Given this list of marker genes Rps27a, Cdc20, Uba52, Ubb, Fzr1, Ubc, Fbxo5, Uba52rt, Cul1, Skp1, here is a description of the gene set: Mouse Gene Set: REACTOME_SCF_BETA_TRCP_MEDIATED_DEGRADATION_OF_EMI1 species: Mus musculus SCF-beta-TrCP mediated degradation of Emi1